Given this list of marker genes Frat2, Aknad1, Gm11228, 2900052L18Rik, Synpo, Esr1, Pgk1, Crygf, Usp1, here is a description of the gene set: Mouse Gene Set: BARX1_TARGET_GENES from publication Yevshin I, Sharipov R, Kolmykov S, Kondrakhin Y, Kolpakov F (PMID 30445619) Genes containing one or more binding sites for (Barx1) in their promoter regions (TSS -1000,+100 bp) as identified by GTRD version 20.06 ChIP-seq harmonization. studied in species Mus musculus